The following is a description of a gene set: studied in species Homo sapiens Genes predicted to be targets of miRBase v22 microRNA hsa-miR-4497 in miRDB v6.0 with MirTarget v4 prediction scores > 80 (high confidence targets). Human Gene Set: MIR4497 from publication Chen Y, Wang X (PMID 31504780), and this is the list of marker genes: NRN1, TRERF1, BOK, ARFRP1, KCNA3, MED13L, METTL21A, APPBP2